The following is a description of a gene set: studied in species Homo sapiens Human Gene Set: HP_ICHTHYOSIS Ichthyosis An abnormality of the skin characterized the presence of excessive amounts of dry surface scales on the skin resulting from an abnormality of keratinization., and this is the list of marker genes: ERCC2, ASPRV1, FLG, NIPAL4, SPINK5, LSS (lanosterol synthase), ALDH3A2, STIM1, IL2RB, PEX3, EFL1, PEX16, ERCC3, ARSL, NSDHL, NDNF, GTF2E2, POMP, PROK2, PIGL, LIPN, ELOVL1, AP1B1, ST14, TGM1, PEX12, SLC27A4, MPDU1, KANSL1, STS, WDR11, PEX6, VPS33B (NCBI Gene Id 55513), HS6ST1, CERS3, KRT1, GJB6, SYNE2, PEX14, FGF17, ALOX12B, HRAS, IL17RD, TGM5, PEX19, PEX10, ALOXE3, SULT2B1, GNB2 (NCBI Gene Id 96628), DUSP6, SHOC2, DBR1, LORICRIN, SOX10, PNPLA2, RIN2, MSMO1, FEZF1, SUMF1 (NCBI Gene Id 285362), SRD5A3, TMEM43, FHL1, SGPL1, HESX1, CCDC141, KRT9, MAP2K2, SPRY4, PEX5, CYP4F22 (cytochrome P450 family 4 subfamily F member 22), CHD7, NRAS, GINS1, FGFR1, MBTPS2, CWC27, PROKR2, DCC, KLK11, PNPLA1, EBP, DOLK, DNAJC21, RNF113A, AP1S1, CLDN1, PHGDH, LMNA, SYNE1, MPLKIP, ELOVL4, ABHD5, ORAI1, NOD2, FLRT3, PPP1R13L, ANOS1, GBA1, SLURP1, MARS1, CARMIL2, PHYH, CHKB, AARS1 (NCBI Gene Id 16), GTF2H5, CARD14, COL4A5, PEX2, DSG1, ITGB6, PEX11B, FGF8, KRT2, CARS1, MAP2K1, SDR9C7 (NCBI Gene Id 121214), SEMA3A, PEX26 (NCBI Gene Id 55670), SBDS, PEX13, PSAT1 (NCBI Gene Id 29968), ABCA12, SREBF1, KRT16 (keratin 16), CSTA, BRAF, SNAP29, NEK9, FITM2, PEX7 (peroxisomal biogenesis factor 7), PIGA (phosphatidylinositol glycan anchor biosynthesis class A), TARS1, EMD, SLC29A3 (NCBI Gene Id 8072), AHSG, VIPAS39, GJB2, KRT10, PEX1 (NCBI Gene Id 7788), KRAS, TACR3, DSP, KDSR, NLRP3, SMARCA2